Given this list of marker genes NFU1, TNFSF11, COL4A1, CACNA1A, TCIRG1, MTRFR, ATP1A2, CLCN7, SH3TC2, PRRT2, SCN1A, here is a description of the gene set: Human Gene Set: HP_FACIAL_PARALYSIS studied in species Homo sapiens Complete loss of ability to move facial muscles innervated by the facial nerve (i.e., the seventh cranial nerve). Facial paralysis